Given this list of marker genes IFNGR2, IFNL1, TYK2, IFNL4, IFNG, IL10RB, IFNLR1, IFNL3, EPG5, SHFL, JAK1, IFNGR1, IFNL2, here is a description of the gene set: Any process that results in a change in state or activity of a cell or an organism (in terms of movement, secretion, enzyme production, gene expression, etc.) as a result of a type III interferon stimulus. Interferon lambda is the only member of the type III interferon found so far. Human Gene Set: GOBP_RESPONSE_TO_TYPE_III_INTERFERON studied in species Homo sapiens